The following is a description of a gene set: Human Gene Set: GOBP_GDP_L_FUCOSE_METABOLIC_PROCESS The chemical reactions and pathways involving GDP-L-fucose, a substance composed of L-fucose in glycosidic linkage with guanosine diphosphate. species: Homo sapiens, and this is the list of marker genes: FPGT, FUOM (fucose mutarotase), GMDS, FUT8, FCSK, GFUS, SLC35C1